Given this list of marker genes Rimbp2, Cacna1b, Erc1, Rims2, Rims1 (NCBI Gene Id 77473), Erc2, Prrt2, here is a description of the gene set: species: Mus musculus Mouse Gene Set: GOBP_REGULATION_OF_CALCIUM_DEPENDENT_ACTIVATION_OF_SYNAPTIC_VESICLE_FUSION Any process that modulates the frequency, rate or extent of calcium-dependent activation of synaptic vesicle fusion.